Given this list of marker genes Sqstm1, Ubxn1, Sharpin, Zranb1, Ikbkg, Zfand6, Ubl7, Zbtb1, Optn, Abraxas1, Sprtn, Dzip3, Tab3, Tnip3, Tnip2, Ikbke, Otud7b, Rnf168, Tab2, Rnf31, Parp10 (NCBI Gene Id 671535, poly (ADP-ribose) polymerase family, member 10), Agap3, Ascc2, Vcp, Rad23a, Dnajb2, Babam2, Nploc4, Mpnd, Prpf8, Brcc3dc, Wdr81, Afg2b, Ubqlnl, Tnip1, Ubqln4, Eps15, Ubqln2 (ubiquilin 2), Agl, Otud7a, Psmd4, Tnfaip3, Bag6, Ubqln5, Ubqln3, Zranb3, Hdac6 (NCBI Gene Id 20374), Ufd1, Ubac1 (ubiquitin associated domain containing 1), Abraxas2, Atrip, Rad23b, Rnf169, Ubqln1, Mindy2, Rad18, Zfand2b, Tom1, Faap20, Brcc3, Mindy1, Uimc1, here is a description of the gene set: studied in species Mus musculus Mouse Gene Set: GOMF_POLYUBIQUITIN_MODIFICATION_DEPENDENT_PROTEIN_BINDING Binding to a protein upon poly-ubiquitination of the target protein.